Given this list of marker genes AKAP8L, CAVIN1, CHMP1B, ZNF623, HSPA1A, SDC1, ZSWIM4, PRSS46P, ESAM, CKAP4, SPATA2, GZMA, USP19, CAVIN3, IMPACT, PPIP5K1, CLOCK, TSPAN17, NAA30, OIT3, SENP6, GTPBP2, PAXBP1, NATD1, PON3, TFPI2, TIAM1, TCIRG1, ARHGAP12, MYRF, UFD1, CAB39L, TTC17, FBXO33, FASLG, VOPP1, HSPA1B, PEX11G, MAP3K6, MCOLN1, CYTH2, GPR35, SHISA2, COPS7B, ADHFE1, YPEL2, DPP8, INPP5F, BTBD1, IFNAR2, SIAH1, LSM14B, PLEKHF1, MIEF1, ESF1, DOCK7, PSAT1, EEF1A2, MAMLD1, RPIA, TMEM158, PTPRE, SLC25A51, GDF9, LGR4, MOCS2, GOLGA7, IL6ST, AK8, PEX16, TEP1, SLC41A2, ASPA, PBX1, LAT, G0S2, MFSD4B, ITPK1, ATL3, SNX33, CCDC88A, UBQLN1, SLC37A4, CD300C, MTDH, TMEM69, RNPC3, PGRMC1, TANC2, RALGAPB, HMGA1, KRI1 (KRI1 homolog), MICALL1, UTP18, ALDH1B1, NEDD9, SLC25A13, CCL25, RPS6KB1, NLK, DDX27, PLEKHA5, CSNK1A1, MPC2, P2RY1, SLC35B3, EPB41L1, REL, ABHD11, SNHG12, TBC1D2B, ZNF131, MALAT1, KCNG1, RAI14, CSRNP2, TMEM33, FAM43A, BAG3, ALDH3B1, SLC48A1, IL3RA, TBRG1, LARP4B, TMEM39B, SH3TC1, WSB2, DIP2C, RASL11B, DET1, GALNT7, PTGFRN, GRAMD4, UBA6, TACC2, EMC4, NLN, ZCCHC2, SMAD5, UBE2F, ANGPTL2, CEP68, MATK, MFAP3L, CFAP418, COLGALT1, ARHGAP5 (NCBI Gene Id 394), UBASH3B, TPCN2, GOLGA5, GDA, RPS15A, HADHB, SFT2D2, MMP19, CDKN2AIP, PDCD6, ZYG11B, NLRP10, CLDN11, DENND4B, CDK20, FAM20B, ARL6IP5, MAPK1 (NCBI Gene Id 5594), CMPK1, GLA, NUDT19, MREG, SORT1, MRI1, TRIP12, PRDX3, TSPAN3, SNX1, CELSR1, POLR1F, VSIG8, CCAR1, ATF1, PRG4, HDAC7 (NCBI Gene Id 51564), GABPA, PER1, AKAP1, PLPP1, AMZ1, NAE1, C7orf25, WDR74, POLR3E, NXF1, ADPRH, CHMP7, RETSAT, ERMP1, PLCD1, PCYOX1L, TTC33, here is a description of the gene set: IL-10 or IL-6 stimulation of control 129xC57BL/6 murine bone marrow derived macrophages in the presence of LPS. We used microarrays to detail the global programme of gene expression changes in response to IL-6 or IL-10 stimulation in the presence of lipopolysaccharide. BMDMs were isolated from control, IL-6-/-, and IL-10-/- mice on a 129XBL/6 mixed background mice and differentiated in the presence of CSF-1 for 6-7 days. Cells were scraped and plated in 6 well plates at 2x10e6/well. Cells were washed with complete DMEM and rested for 1-2 hr before stimulation with combinations of IL-10 (10 ng/ml), IL-6 (2 ng/ml) or LPS (100 ng/ml) for 45 min or 180 mins. Complete biological replicates were performed. species: Homo sapiens Genes down-regulated in bone marrow-derived macrophages at 45 min of stimulation by LPS: wildtype versus IL10. from publication El Kasmi KC, Holst J, Coffre M, Mielke L, de Pauw A, Lhocine N, Smith AM, Rutschman R, Kaushal D, Shen Y, Suda T, Donnelly RP, Myers MG Jr, Alexander W, Vignali DA, Watowich SS, Ernst M, Hilton DJ, Murray PJ (PMID 17114459) Human Gene Set: GSE5589_WT_VS_IL10_KO_LPS_STIM_MACROPHAGE_45MIN_DN